The following is a description of a gene set: species: Homo sapiens Any process that modulates the frequency, rate or extent of synapse assembly, the aggregation, arrangement and bonding together of a set of components to form a synapse. Human Gene Set: GOBP_REGULATION_OF_SYNAPSE_ASSEMBLY, and this is the list of marker genes: LRFN5, RAC3, ABI3, SRGAP2, TRIM47, EPHA7, NAE1, RHOG, LRP4, CHRNB2, PTPRS, DLG5, CTNNB1, AMIGO3, EFNA5, LRFN4, DKK1, SIX4, CBLN1, LINGO2, PPP1R9B, PTPN13, NRXN1, IQSEC2, RTN4R, LIN7A, CUX2, WNT5A, GHRL, CYFIP2, VSTM5, NEGR1 (neuronal growth regulator 1), MEF2C, SIGMAR1, SLITRK1, PTPN1, THBS2, FLRT3, ELMO1, PRKCA, ADNP, SLIT1, CRTAC1, CBLN2, LIN7B, SLITRK6, RAB17, LRFN3, CLSTN2, ROBO2, LRFN1, ARMCX5-GPRASP2, MIR431, NTN1, WNT7A, DOCK4, FLRT1, LRRTM2, LATS1, ST8SIA2, HTR4, NLGN2, LIN7C, CRMP1, CASKIN1, NCKIPSD, ZDHHC8, WNT3A, LRTM2, CRIPT, SENP1, NEDD8 (NEDD8 ubiquitin like modifier), ASIC1, MARK1, TLR2, ARF6, NTRK2, EPHB3, PDZD11, PTPRD, SEMA4A, SLITRK4, OGT, IL1RAPL1, LRRTM3, SIX1, GNA13, BDNF, EPHB1, ICAM5, ARHGAP12, NTRK1 (NCBI Gene Id 7825), ADGRB3, NLGN3, NLGN1, ARHGAP33, ARHGEF15, PRICKLE1, FLRT2, NEURL1, FZD1, RAP2A, SLITRK3, FGFR1, ASIC2, UBE2M, PTK2B, LHFPL4, COLQ, ADGRB2, IL1RAPL2, PDLIM5, VLDLR, LRRN1, EIF4G1, SETD5, RTN4, OXT, GPRASP3, ADGRB1, CLSTN1, EEF2K, GPC4, RAC1, SYNDIG1, MDGA1, GHSR, MAP1B, LRRC24, PUM2, NECTIN3, GRID2, S1PR2, DOCK1 (dedicator of cytokinesis 1), MUSK, VPS35, CARMIL3, SLITRK5 (NCBI Gene Id 26050), LZTS1, APP, NECTIN1, NTNG2, IL1RAP, AMIGO2, CC2D1A, SEMA4C (semaphorin 4C), LINGO4, AMIGO1, STAU2, NUMBL, DOCK10, NTRK3, TPBG, SRGAP2C, SNCA, NLGN4X, SRPX2, SLC12A5, CHD4, FARP1, AGRN, SRGAP2B, SLITRK2, EPHB2, LRRC4B, SEMA4D, UBE3B, CLSTN3, IGSF11, MYCBP2, NRXN2, LRRTM1, LRRN3